Given this list of marker genes EED, TRIP11, NANS, PEX5, VPS33A, HSPG2, GNPNAT1, LIFR, CCN6, MMP13, LYSET, EIF2AK3, RPS6KA3, NEPRO, COG1, ERCC6, DDR2, B3GALT6, SEC23A, SOX9, TRAPPC2, HLA-B, GLB1 (galactosidase beta 1), SEC24D, PHEX, WNT7A, HDAC6, IHH, DLK1, LMX1B, GPC3, ACP5, GPX4, ATP7A, ENPP1, DYM, KAT6B, GNAS (GNAS complex locus), LAMA5, INPPL1, AMER1, CREBBP, POP1, BGN, PCNT, IDUA, COL11A1, ZBTB20, GUSB, EZH2, MATN3, CEP120, IDH1, TNFRSF1A (NCBI Gene Id 8077), WDR19, PLCB3, FLNA, TRPV4, COL2A1 (collagen type II alpha 1 chain), EXTL3, PAM16, MAN2B1, SLC26A2, DMP1, COL9A1, GNPTG, ARSB, PTH1R, PCYT1A, TBX15, FGFR3, RIPK4, MEG3, FUZ, FN1, GNPTAB, SLC35D1, ERCC8, PIGN, FLNB (filamin B), EP300, PLEKHM1, EVC2, TMEM67, COL11A2, LONP1 (NCBI Gene Id 9361), SMAD4, NKX3-2, RMRP, RUNX2, AIFM1, GALNS, AEBP1, EVC, VANGL1, RAB23, RTL1, RPS19, GPC4, IFT81, CTSK, CCBE1, TWIST2, RNU4ATAC, POLR3A, here is a description of the gene set: Human Gene Set: HP_ABNORMAL_ILIUM_MORPHOLOGY studied in species Homo sapiens An abnormality of the ilium, the largest and uppermost bone of the pelvis. Abnormal ilium morphology